Given this list of marker genes ACP2, ACP6, MDP1 (NCBI Gene Id 145553), ACP1, ACP5, MINPP1, ACP3, ACP4, ACP7, here is a description of the gene set: Human Gene Set: GOMF_ACID_PHOSPHATASE_ACTIVITY Catalysis of the reaction: an orthophosphoric monoester + H2O = an alcohol + phosphate, with an acid pH optimum. species: Homo sapiens